Given this list of marker genes FBXL4, NDUFB10, ALDH5A1, CA5A, ACADM, ALDH6A1, HMGCS2, BCKDHA, HGD, OXCT1, UPB1, AGXT, here is a description of the gene set: species: Homo sapiens Elevated urinary monocarboxylic acid level Abnormally increased amount of a monocarboxylic acid in the urine. Monocarboxylic acids are molecules with one COOH functional group. Human Gene Set: HP_ELEVATED_URINARY_MONOCARBOXYLIC_ACID_LEVEL